The following is a description of a gene set: Human Gene Set: GSE17974_CTRL_VS_ACT_IL4_AND_ANTI_IL12_48H_CD4_TCELL_DN from publication Elo LL, Järvenpää H, Tuomela S, Raghav S, Ahlfors H, Laurila K, Gupta B, Lund RJ, Tahvanainen J, Hawkins RD, Oresic M, Lähdesmäki H, Rasool O, Rao KV, Aittokallio T, Lahesmaa R (PMID 20620947) species: Homo sapiens Genes down-regulated in comparison of untreated CD4 T cells at 0 h versus the cells treated with IL4 and anti-IL12 at 48 h. The aim of this dataset was to study in detail the transcription kinetics initiated by cytokine IL-4 in early differentiation of Th2 cells., and this is the list of marker genes: AK2, PSMD8, MACROD1, C12orf75, TXNDC15, SLC7A1, IL2RG, GOT2, PRC1, WRAP53, NUDT6, NTPCR, TDP1, CENPJ, SYT11, COMMD4, ZFP57, ATG7, MCOLN2, ELOVL4, RBKS, MRPS26, CORO1B, SEPHS1, ERG28, FAF1, IFT25, CCDC34, GSTP1, HIRIP3, FNTB, PDHA1, MRPL19, PRDX4, WDR54, MEA1, PTTG1, SLC29A1, PIF1, SSU72, SLC39A14, RAD51D, LSM4, GNG5, ARL3, OGFOD2, POP4, MED21, PCBD1, TMEM273, CKS1B, FAM83D, HMGB3, TMEM165, GPN3, GPI, POLD2, RNPEP, HSCB, CDCA3, CREB3, HCP5, MIR3142HG, EGLN3, TMEM121, HDHD5, TRAP1, NEMP1, FAH, GTDC1, TBL2, PSRC1, IGSF3, SARS2, CAAP1, SCFD2, BDH1, MTMR2, SERPINH1, CDK2AP1, RUVBL2, GSTO1, ATOX1 (NCBI Gene Id 475), CCDC126, DNAJC17, POLR2H, PAAF1, CACYBP, AURKA, ARMT1, SDHAF4, ACAA2, SLC25A20, SFT2D1, LZIC, FAM98B, TMEM106C, LEO1, MRPS28 (mitochondrial ribosomal protein S28), LINC01128, ZMYM6 (NCBI Gene Id 9204), LRRC42, KIF2A, ZNF410, SLC25A43, RCC1L, HAUS4, NFE2L3, MIF, APOBEC3G, KLHL17, ZWILCH, LYAR, C9orf40, OST4, BRIP1, TXNL4A, TFDP1, PAM, FAR2, TP53BP1, MYH10, CDC25C, POLR3D, NIT2, NRM, MRM2, MOB3C, SAPCD2, HLTF, UCK2, ACY1, MCM5, GNA15, RNF8, IDH2, GLB1, TMEM45A, SPC24, ATP1B3, DYNLT2B, CTNNAL1 (NCBI Gene Id 8727), DHPS, KEAP1, ZNF780A, CCL22, COX5A (cytochrome c oxidase subunit 5A), BCAT2, NSD2, ISCA2, PHPT1, ACAT1, FPGT, CSTF3, RHOF, TMEM53, FEN1, PPID, BOLA1, EZH2, HNRNPA2B1, MAP3K20, ARF6, ECI2, SIT1, ETFB, CEP152, WDR3, PLIN2, WDHD1, MED20, RRAGA, CRNKL1, RMI1, C1GALT1C1, VRK1, TBC1D19, THYN1, ECI1, METTL8, TPD52, MRPL17, DNAAF10, COX6A1, KISS1R, SALL2, NUP160, TMUB1, GPANK1, PSMB2, SNAPC3, CASP6, KRT10-AS1, PRIM1 (NCBI Gene Id 5557), PHF19, SNRNP25, OSBPL3, DTYMK, TWF2